The following is a description of a gene set: species: Mus musculus Mouse Gene Set: chr5E1, and this is the list of marker genes: Gm24129, Albfm1, Prr27, Tmprss11d, Smr2, BC051076, 2900064F13Rik, Csn2, Utp3, Gm9958, Uba6, Gm7721, Afp, Cxcl1, Gm25765, Gm24524, Cxcl3, Gm19619, Gm31230, Odam, Slc4a4, Ambn, Tmprss11b, Rufy3, Eif5al3-ps, Sult1e1, Gm21006, Gm7631, Afm, Gm21461, Amtn, Ugt2b37 (NCBI Gene Id 112417), Gm7048, Ugt2b34, Ppbp, Csn1s2a, Idi1-ps2, Mob1b, Gm2287, Gm15682, Csn3, Gm5869, 1700031L13Rik, Gnrhr, Gm7709 (predicted gene 7709), Gm21043, Gm4866, 1700008H02Rik, Epgn, Ankrd17, Rassf6, Gm19610, Tecrl, Areg, Cabs1, Prol1, Gm7337, Npffr2, Gm18635, Sult1b1, Gm20121, Gm42164 (predicted gene, 42164), Mkrn1-ps1, Gc, Rpl7-ps7, Ugt2b35, Adamts3, Ugt2a1, Ugt2b1, Mir1187, Gm7652, Smr3a, Tmprss11e, Alb, Mthfd2l, Gm2602, Mir3969, Smr2l, Cenpc1, Stap1, Ugt2a3, Csn1s2b, Dck, Gm25758, Ugt2b38, Enam, Ythdc1, Epha5, 2310003L06Rik, Ugt2b36, Ugt2a2, Cxcl2, Ugt2b5, Pf4, Cxcl15, Jchain, Gm7646, Ereg, Tmprss11f, Gm42109, Gm42622, Gm5717, Gm43217, Cxcl5, Gm21049, 1700066N21Rik, Csn1s1, Gm19418, Sult1d1, Grsf1, Gm25806, Tmprss11g, Tmprss11c, Gm24121, Hmgn2-ps1, Gm6366, Gm24626 (predicted gene, 24626), Gm24792, BC037156, Cox18, Tmprss11a